The following is a description of a gene set: A signaling process that contributes to a meiotic cell cycle checkpoint that ensures accurate chromosome replication and segregation by preventing progression through a meiotic cell cycle until conditions are suitable for the cell to proceed to the next stage. studied in species Mus musculus Mouse Gene Set: GOBP_MEIOTIC_CELL_CYCLE_CHECKPOINT_SIGNALING, and this is the list of marker genes: Ttk, Rad1, Zfy2, Chfr, Hus1b (HUS1 checkpoint clamp component B), Hus1, Zwint, Trip13, Hormad1, Knl1 (NCBI Gene Id 76464), Nsun2